Given this list of marker genes PEX19, CPT2, PEX5, PEX1 (peroxisomal biogenesis factor 1), ABCD1, here is a description of the gene set: Elevated circulating long chain fatty acid concentration Increased concentration of long-chain fatty acids in the blood circulation. species: Homo sapiens Human Gene Set: HP_ELEVATED_CIRCULATING_LONG_CHAIN_FATTY_ACID_CONCENTRATION